The following is a description of a gene set: from publication Schaefer CF, Anthony K, Krupa S, Buchoff J, Day M, Hannay T, Buetow KH (PMID 18832364) species: Homo sapiens Human Gene Set: PID_S1P_S1P3_PATHWAY S1P3 pathway, and this is the list of marker genes: AKT1, GNA15, VEGFA, RAC1, S1PR1, S1PR3, GNAI2, PDGFB, GNA14, GNAI1, GNA12, CXCR4, SRC, FLT1, GNA13, S1PR2, GNA11, JAK2, MAPK1, GNAZ, GNAQ, PDGFRB, ITGAV (NCBI Gene Id 7449), RHOA (ras homolog family member A), MAPK3, GNAO1, ITGB3, GNAI3, AKT3